The following is a description of a gene set: Human Gene Set: HP_PERIMEMBRANOUS_VENTRICULAR_SEPTAL_DEFECT A ventricular septal defect that is confluent with and involves the membranous septum and is bordered by an atrioventricular valve, not including the type 3 VSDs. species: Homo sapiens Perimembranous ventricular septal defect, and this is the list of marker genes: NDUFC2, ATRX, GJA8, ALG8, THOC6, FH, MYH7, CITED2, COG7, CALM3, EP300, NDUFB7, PUF60, ERI1, GATA6, CHD3, GJA5, NUP188, SEC31A (NCBI Gene Id 51424), TBX5, RAD21 (NCBI Gene Id 5885), NAA10, CLXN, MEIS2, BMP2, CREBBP